The following is a description of a gene set: Mouse Gene Set: GOBP_RESPONSE_TO_SYMBIONT species: Mus musculus Any process that results in a change in state or activity of a cell or an organism (in terms of movement, secretion, enzyme production, gene expression, etc.) as a result of a stimulus from a symbiont, an organism living with an organism of a different species in close physical association. The symbiont is defined as the smaller of the organisms involved in a symbiotic interaction., and this is the list of marker genes: Gpx1, Reg3g, Slc22a5, Gpx2, C4bp, Slc22a21, Zp3r, Ptafr